Given this list of marker genes CDR2, CDR2L, SERPINE1 (NCBI Gene Id 5054), ETS2, PPP1R15A, MYC, MAP2K3, ACKR3, ADM, FOSB, TNFRSF1B, CCN1, SEMA3C, ID3, THBS1, PTGS2, ZFP36, RHOB, NR4A1, KLF4, CEBPD, DNAJB6, BTG2, DNAJB4, FOS, EMD, PHLDA1, BAG3, GADD45G, IER3, DUSP1, CCN2, NR4A2, TNFAIP6, LONP1, SLC20A1, DNAJB1, FOXC2, RGS2, ERRFI1, JUNB, RHOJ, HK2, CAPN1 (NCBI Gene Id 823), IL6 (NCBI Gene Id 3569), here is a description of the gene set: Cluster 2: genes maximally expressed at 2 h time point during differentiation of 3T3-L1 fibroblasts into adipocytes (cluster 2) in response to adipogenic hormones. The molecular mechanisms that regulate cellular differentiation during development and throughout life are complex. It is now recognized that precise patterns of differentially expressed genes ultimately direct a particular cell toward a given lineage and many of these are regulated during the earliest stages of differentiation. Using a microarray-based expression analysis, we have examined gene expression profiles during the first 24 h of 3T3-L1 adipocyte differentiation. RNA was isolated at times 0, 2, 8, 16, and 24 h following stimulation of differentiation and hybridized in duplicate to high density Affymetrix microarray gene chips containing a series of 13,179 cDNA/expressed sequence tag (EST) probe sets. Two hundred and eighty-five cDNA/ESTs were shown to have at least a fivefold change in expression levels during this time course and both hierarchical and self-organizing map clustering analysis was performed to categorize them by expression profiles. Several genes known to be regulated during this time period were confirmed and Western blot analysis of the proteins encoded by some of the identified genes revealed expression profiles similar to their mRNA counterparts. As expected, many of the genes identified have not been examined in such a critical time period during adipogenesis and may well represent novel adipogenic mediators. Human Gene Set: BURTON_ADIPOGENESIS_PEAK_AT_2HR studied in species Mus musculus from publication Burton GR, Guan Y, Nagarajan R, McGehee RE Jr (PMID 12137940)